Given this list of marker genes LTK, GRB2, TNK2, ALKAL2, PIK3CB, PIK3R1, SHC1, ALKAL1, IRS1, PIK3CA, SOS1, PIK3R2, here is a description of the gene set: Signaling by LTK species: Homo sapiens Human Gene Set: REACTOME_SIGNALING_BY_LTK